Given this list of marker genes Mbd3, H4c1, H3c4, H2bc7, H2ac24, Nr2c2, Mta2, H4c8, H4c18, Mta1, H2ac4, H2bc13, H2ac12, H2bc9, H2bc1, H3c10, H4c17, Mbd2, H2bc27, H2ac6, H4c6, H2bc8, H2ax (H2A.X variant histone), H3f3a (NCBI Gene Id 15078), H4c3, H2ac15 (NCBI Gene Id 319169), Rbbp7, H2ac23, H4c4, H3c2 (NCBI Gene Id 319150), H2az2, H3c7, Zfp687, H2ac11, H2bc11, Mbd3l2, Sumo1, H3c6, H2bc22, H2ac1, H4c9, H3c15, H2bc3, H4c2, H2ac22, H2ac19, H2ac10, H2bc15, H2bc12, H4c14, H2ac20, Pwwp2a, Zfp532, H4c12, H3c11, H2ac7, H4c11, H3c8, H3c13, Rbbp4, H3c3, H2ac13, H2ac8, H3c1, here is a description of the gene set: Reactome Pathway: NuRD complex assembly This event has been computationally inferred from an event that has been demonstrated in another species.<p>The inference is based on the homology mapping from PANTHER. Briefly, reactions for which all involved PhysicalEntities (in input, output and catalyst) have a mapped orthologue/paralogue (for complexes at least 75% of components must have a mapping) are inferred to the other species. part of: CHD3, CHD4, CHD5 subfamily electronically inferred by orthology from the curated human pathway species: Mus musculus